Given this list of marker genes Csnk2b, Pip5k1b, Csnk2a1, Dvl3, Dvl1, Csnk2a2, Dvl2, Csnk1e, here is a description of the gene set: studied in species Mus musculus Mouse Gene Set: REACTOME_WNT_MEDIATED_ACTIVATION_OF_DVL WNT mediated activation of DVL